Given this list of marker genes TMEM102, DNMT1, IFT27, ABCB10, DUSP2, NELFA, CTSW, AAMDC, PTPRCAP, METTL23, ITK, DOCK2, ATP5PF, TAP2, SH2D1A, CD27, ITGA4, STAT1, SETDB2 (NCBI Gene Id 83852), IL2RG (interleukin 2 receptor subunit gamma), TANGO6, PML, PRKCQ, CD3G, BLVRB, HLCS, LETMD1, GZMB, CD300LD, GIMAP6, SGCE, DNASE1L3, CXCR6, KEAP1, CST7, TNFRSF18, TAP1, RBM28, IL18BP, RGS16, GGH, GZMA, CD7, GALNT10, PDK1, MAP1S, APOBEC3B, SPN, LY9, SMAGP, NXPE4, ITPA, SERF2, LY6E, PPP1R16B, UBAP2L, HLA-C, ERAL1 (NCBI Gene Id 26284), PARP11, CD28, SEPTIN6, LAT, ARHGAP39, UNC93B1, CALHM2, CDPF1, ZBTB32, KLRC1, EGFL8, C9orf152, CD2, CREB3L1, TBC1D24, NLRC5, PPM1H, CD200R1L, KGD4, CD247, IL2RB, TOX, ACTR3B, VILL, LCK, ADAM17 (NCBI Gene Id 6868), H2AC25, BAIAP3, ADRB1, IKZF3, CD6, KLRD1, TXK, PHGDH, PPP5C (NCBI Gene Id 5536), SLC25A19, SEMA4D, PGLYRP2, PRF1, PRKCH, ENTPD6, FADS6, RAD23A, GZMK, H2AB2, BATF2, HLA-B, SKAP1 (NCBI Gene Id 8631), MFSD11, PLEKHG1, ENTREP3, MTHFD2, OGFR, MNS1, GTSE1, HRH2, NXPE3, ATP6V1D, AOAH, RBBP8, TMCC2, ZBP1, PADI2, SLAMF7, CYP2R1, IL3RA, CD3E, FYN, ACSF3, PDCD1, CISD3, EPSTI1, IGHM, PTPRC, ANG, RPGRIP1, NR1H3, AFMID (NCBI Gene Id 125061), TSPAN32, ZMAT5, PNP, IL12RB1, ACVRL1, GEM (GTP binding protein overexpressed in skeletal muscle), SH2D2A, SYTL2, CD8B, STAT2, GIMAP8, CD180, BATF3, SCARF1, RIOX2, BID, MRPS16, RMND1 (NCBI Gene Id 55005), THY1, SLC13A3, PMF1, CYRIA, NKG7, TBCB, TBX21, DPP4, CTLA4, FASLG, HAUS5, RBFA, LAG3, PTP4A2 (protein tyrosine phosphatase 4A2), GIMAP7, DPYSL3, CD3D, TRAF5, LACC1, IRF1, GIMAP4, PARP3, HLA-E, NCR1, CLDND1, TMEM71, TRAF2, CD5, EFHD2, CCL5, STAT4, GPR162, CD79B, GBP2, FOXP1, ICAM2 (NCBI Gene Id 3384), LPL, SLC11A2, IFNG, GPRASP3, ARHGAP19, UBASH3B, GIMAP1, THEMIS, HCK (NCBI Gene Id 3055), SRGAP2, here is a description of the gene set: Three innate (B1-B, NKT, CD8aaT cells) and adaptive (B2-B, CD4T, CD8abT cells) cell-types were sorted by FACS. Three biological replicates for NKT, CD4T, CD8aaT, CD8abT cells and two biological replicates for B1 and B2 cells were generated and the expression profiles were determined using Affymetrix Mu74Av2 chip. Comparisons between the sample groups allow the identification of genes differentially expressed between the innate and adaptive cell-types. Genes down-regulated in NKT cells versus CD8A T cells. species: Homo sapiens Human Gene Set: GSE3039_NKT_CELL_VS_ALPHAALPHA_CD8_TCELL_DN from publication Yamagata T, Benoist C, Mathis D (PMID 16623764)